Given this list of marker genes SLC20A1, CDH1, LDLR, RRBP1, SYT17, RFTN1, RAB27A, HES1, CMTM6, GATA6, SDC4, TNS1 (tensin 1), NUP98, TNFSF10, TRIM15, LSR, OSBPL9, INPP1, AGO2, here is a description of the gene set: species: Homo sapiens from publication Boyault S, Rickman DS, de Reyniès A, Balabaud C, Rebouissou S, Jeannot E, Hérault A, Saric J, Belghiti J, Franco D, Bioulac-Sage P, Laurent-Puig P, Zucman-Rossi J (PMID 17187432) Human Gene Set: BOYAULT_LIVER_CANCER_SUBCLASS_G6_DN Down-regulated genes in hepatocellular carcinoma (HCC) subclass G6, defined by unsupervised clustering. Hepatocellular carcinomas (HCCs) are a heterogeneous group of tumors that differ in risk factors and genetic alterations. We further investigated transcriptome-genotype-phenotype correlations in HCC. Global transcriptome analyses were performed on 57 HCCs and 3 hepatocellular adenomas and validated by quantitative RT-PCR using 63 additional HCCs. We determined loss of heterozygosity, gene mutations, promoter methylation of CDH1 and CDKN2A, and HBV DNA copy number for each tumor. Unsupervised transcriptome analysis identified 6 robust subgroups of HCC (G1-G6) associated with clinical and genetic characteristics. G1 tumors were associated with low copy number of HBV and overexpression of genes expressed in fetal liver and controlled by parental imprinting. G2 included HCCs infected with a high copy number of HBV and mutations in PIK3CA and TP53. In these first groups, we detected specific activation of the AKT pathway. G3 tumors were typified by mutation of TP53 and overexpression of genes controlling the cell cycle. G4 was a heterogeneous subgroup of tumors including TCF1-mutated hepatocellular adenomas and carcinomas. G5 and G6 were strongly related to beta-catenin mutations that lead to Wnt pathway activation; in particular, G6 tumors were characterized by satellite nodules, higher activation of the Wnt pathway, and E-cadherin underexpression. CONCLUSION: These results have furthered our understanding of the genetic diversity of human HCC and have provided specific identifiers for classifying tumors. In addition, our classification has potential therapeutic implications because 50% of the tumors were related to WNT or AKT pathway activation, which potentially could be targeted by specific inhibiting therapies.